Given this list of marker genes Irx2, Sostdc1, Dspp, Npr3, Egr3, Mesp1, Lrp5, Tulp3, Hs6st1, Gpx1 (NCBI Gene Id 14775), Fyn, Prrx1, Tbx4, Rgcc, Plg, Rbpj, Chi3l1, Jmjd8, Csmd1, Ptk2, Adam15, Hnf1b, Anxa1, Minar2, Ift57, Ptpn6, Traf6 (NCBI Gene Id 99098), Ephb3, Tcf7l2, Vangl2, Lep, Vegfb, Ctns, Ets1, Shroom3, Angptl6, Adrb2, Sall4, Tnfaip2, Ctnnbip1, Pank2, Vegfc, Rara, Pax2, Tnn, Hgf, Nr2f2, Itgax, Gpr15, Pfn1, Wdr83 (WD repeat domain containing 83, NCBI Gene Id 67836), Rapgef3, Tctn1, Timeless (timeless circadian clock 1), Sfrp2, Tert, Aimp1, Efna1, Fzd6, Notch4, Bmper, Itga7, Sema4c, Cd34, Ccl11 (C-C motif chemokine ligand 11), Foxc1, Hs3st3a1, Hbegf, Plcd1, Rnf213 (NCBI Gene Id 672511), Sox9, Gpld1, Sox4, Bcl2l11, Enpep, Ccl12 (NCBI Gene Id 20293), Bbs4, Zfp354c, Ctsl, Igf2, Uts2r, Pik3ca, Cdc42, Smad4 (NCBI Gene Id 28063), Shox2, Sp100, Ptger4, Id2, Btrc, Lef1, Grhl2, Unc5b, Dvl2, Col3a1, Hc, Vav3, Stat1, Fgf18, Fgf1, Srpk2, Foxn4, Hmga2, Ramp2, Mir27a, Ctnnd1, Hdac7 (NCBI Gene Id 56233), Anxa3, Bmpr1a, Wnt7b, Paxip1, Ddah1, Rhoa, Dlg5, Clec14a, Tbx2 (T-box 2, NCBI Gene Id 21385), Hoxa5 (NCBI Gene Id 15402), Itga2b, Tafa5, Cav3, Ctsh, Zic3, Ift122, Pf4, Cd36, Gatad2a, Robo4, Gab1, Kdm2a, Mcam, Ago2, Yjefn3, Mecom (NCBI Gene Id 58253), Epha7, Tnfsf12 (NCBI Gene Id 21944), Stk3, Stil, Fat4, Psg22, Adm (NCBI Gene Id 11535), Ctsz, Stk4, Yap1, Gli3, Amot, Greb1l, Ihh (NCBI Gene Id 16147), Kctd10, Thsd7a, Prl7d1, Atp2b4, Ppp1r16b, Sema4a, Thbs4, Abl2, Gdf2, Prox1, Pik3cg, Myo18b, Ang4, Csnk2b, Efnb2, Notch2 (NCBI Gene Id 99749), Rela, Mylk, Jup, Prkaca, Tgm2, Thbs1, Smad2, Adamts16, Sulf1, Srf (serum response factor), Nphp3, Pten, Epas1, Ccm2, Cnmd, Il10, Naa15, Tnfrsf1a, Myc, Casp3, Pax3, Emilin1, Hes5, Setdb2, Fgfr2, Tal1, Nkx2-5, Pkhd1, Ecm1, Cobl, Prrx2, Spint2, Syk, Rtn4, Id1, Cd40, Krit1, Emcn, Rdh10, Klhl3, Kras, Mir216a, Egfl7, Xbp1, Pknox1, Gpr4, Nkx2-1, Il1b, Myo1e, Sall1, Foxa1, C3ar1, Ramp1, Ndp, Ntrk1, Zeb2, Mthfd1l, Plcd3, Dchs1, Sema6a, Nkx2-3, Lama5, Qki, Smarca4, Gdnf, Areg (amphiregulin), Prkca, Dcn, Fap, Dnaaf1, Nfatc1, Dlg1, Ldlr, Phb2 (prohibitin 2), Jak1, Fgf6, Deaf1, Lmo4, Wnk4, Ccn1, Grn, Fgf8, Pgk1, Fn1, Prl2c2, Mmrn2, Hrg, Tgfbr1, Akt1, Pparg, Meox2, Fmnl3, Mical2, Ephb2, Il18, Cd160, Gadd45a, Igf1, Ghrl, Anxa2 (annexin A2), Cfh, Ppp1r15a, Sox17, Hhex, Mydgf, Srpx2, Dsg2, Tnmd, Tmed2, Tmem100, Fgf2, Actg1, Tmtc3, Dag1, Wnt4, Adgrf5, Ddr1, Notch1, Mef2c, Agtr1a, Tcf7, Nr4a3, Rasip1, Sfrp5 (NCBI Gene Id 54612), Nckap1, Enah, Adgrf4, Stra6, Tfap2c (NCBI Gene Id 98784), Sox10, Ang5, Becn1, Foxj2, Brd2, Irx3, Tmem215, Fasl, Ccdc39, Cldn5, Cfc1, Wasf2, Serpine1, Tnni3, Sgcd, Aplnr, Mir216b, Zfp36l1, Rala, Smad3, Card10, Epn2, Adra2b, Emx2, Sars1, Vhl, Ppp3r1 (protein phosphatase 3, regulatory subunit B, alpha isoform (calcineurin B, type I)), Mir27b, Fgf9, Mmrn1, Apoe, Amotl1, Cfl1, Ski, Cspg4, Hes1, Ngfr, Sp1, Hey1, Mks1, Mib1, Il12a, Rnh1, Col18a1, Vasp, Pik3c2a, E2f2, Tsc2, Ptprj, Hipk2, Mmp19, Pbx1, Tnc, Ephb1, Sox8, Brca1, Etv5, Ift172, Hoxd13, Cx3cl1, Angptl3 (NCBI Gene Id 30924), Hspb1, Rab23, Heg1, Prok1, Ccl5, Trim71, Rora, Foxm1, Pdgfb (NCBI Gene Id 18591), Six1, Mir145a (microRNA 145a), Acvr1, Cav1, Cripto, Tlr3, Src, Mir143, Tjp1, Nkx3-1, Zfpm2, F3, Fkbpl, Vdr, Acvr2b, Eng, Abcc8, Cxcr4, Map3k7 (mitogen-activated protein kinase kinase kinase 7), Prkd2, Plxnd1, Rspo2, Plau, Prdm1, Asb4, Cdh5, Klf5, Spry1, Ccdc103, Lrp2, Pml, Lox, Lrg1, Junb, Kif20b, Vps4b, Vav2, Sema3e, Tead2, Hand2, Bcas3, Mgp, Nr4a1 (nuclear receptor subfamily 4, group A, member 1), Ago1, Cybb, Esm1, Mapk7, Hey2, Pecam1, Nr2e1, Stard13, Plcg1, Has2, Foxf1, Kat6a, Wnt11, Cdk20, Egfr, Ppp1ca, S1pr1, Smad5, Adtrp, Vash1, Egfl8, Clic3, Jag1, Tbx20, Foxa2, Sox18, Cxcr3, Adgrg1, Tiparp, Ccdc40, Ccl2, Agtr2, Msx2, Il12b, Epo, Calcrl, Apold1, Cul7, Nodal, Mapk14 (mitogen-activated protein kinase 14), Pik3r3, Klf2, Zic2, Rock1, Arhgap35, Angpt4, Glul, Dll1 (NCBI Gene Id 13388), Creb3l1, Rxra, Six4, Cluap1, Thy1, Rock2, Tcf21, Fzd8, Pkm, Hoxa11, Adam12, Agr2, Ninj1, Col4a1, Cemip2, Acvrl1, Hgs, Hectd1, Alox5, Rhoj, Mir329, Kdm2b, Smad7, Dysf, Plxnb2, Pgf, Gja1, Sec1, B4galt1, Epb41l5, Nrxn3, Adamts12, Scg2, Wars2, Hspa12b, Aldh1a2, Osr1, Prkacb, Lrp1, Ehd4, Pkd1, Ism1, Dact1, Rbpms2, Scrib, Hoxb3, Cxcr2, Casp8, Col8a2, Nrcam, Esr1, Hdac5, Ptprb, Trp63, Fgfr3, Fzd4, Cx3cr1 (NCBI Gene Id 13051), Cela1, Itgav, Apln, Angpt2, Hoxb13 (NCBI Gene Id 15408), Cib1, Loxl2, Rap1a, Prkcb, Ang6, Mtdh, Adipor2, Ctsd, Gbx2, Mrtfb, Nog, Abl1, Col4a3, Epor, Lias, Ccbe1, Eda, Naxe, Myocd, Rasa1, Fzd3, Zeb1, Nrp2, Epha2, Rtl1, Wnt3a, Or10j5, Apaf1, Mecp2, Ovol2, S2bpcox16, Foxo4, Xdh, Lbx1, Myh9, Cd93, Ccn3, Lcn2, Sh2b3, Cc2d2a, Klf4, Pacsin2, Agt, Tbx1, Itgb2l, Vash2, Grem1, Pspn, Tmem59l, Rarg, Zc3h12a, Rapgef2, Stab1, Ednra, Ccn6, Arhgap24, Sgpl1, Bcl10, Eif2ak3, Tfap2a, Map2k5, Hlx, Psen1, Med12, Cited1, Pdgfra, Bcam, Prok2, Dll4, Htatip2, Pxdn, Adm2, Coq7, Shc1, Pnpla6 (patatin-like phospholipase domain containing 6), Fmn1, Casr, Cysltr2, Kdr, Tcf4, Ccr3, Gpc3, Npr2, Nrxn1, Brpf1, Mir217, Ntn1, Ngp, Cma1, Tek, Tspan12, Nrp1, Plk2, Mir23b, Zmiz1, Ext1, Hdac9, Sema5a, Pdgfrb, Gjc1 (NCBI Gene Id 353069), Stim1, Prickle1, Efna3, Tnfrsf12a, Fut1, Ptk2b, Nfatc4, Gata4, Egln1, Stat3, Prcp (NCBI Gene Id 72461), Notch3, Ntrk2, Flna (filamin, alpha), Foxp1, Elk3, Btg1, Wnt1, Tfap2b, Mia3, Kat2a (NCBI Gene Id 76912), Il17f, Tspan18, Ang (NCBI Gene Id 11727), Eya1, Mdk, Mtss1, Kif26b, Hspb6, Otulin, Cep290, Slc31a1, Itgb1bp1 (integrin beta 1 binding protein 1), Ackr3, Serpinf1 (NCBI Gene Id 20317), Nedd4, Itgb3, Nup50, Rhob, Cysltr1, Nfe2l2, Thbs2, Pitx2, Pik3cb, Egf, Folr1, Adgrb2, Col8a1, Erap1, Lzts2, Ahr, Pik3cd, Med1, Ccn2 (NCBI Gene Id 215862), Hif1a, Pkd2, Runx1, Synj2bp (synaptojanin 2 binding protein), Reck, Cxcl10, Alox12, Angpt1, C2cd3, S100a1, Nrarp, Ptch1, Jam3, Chd7, Smad6, Pde3b, Trp73, Hif3a, Epha1, Hesx1, Ecscr, Arhgap22, Jmjd6, Chrd, Csf1, Meis1, Lhx2, Gja5, Dab2ip, Epn1, Wars1, Smad1, Spint1, Ctnnb1, C3 (complement component 3), Optc, Edn2, BC028528, Isl1, Phactr4, Foxh1, Robo1, Tie1, Met, Wnk1, Bmp4 (bone morphogenetic protein 4), C1galt1, Sparc, Arid1a, Nox1, Esrp2, Nr3c1, Tacstd2, Bax, Mir126b, Tgfa, Hs2st1, Kif3a, Opa1, Dvl1, Pdcl3, Ar, Edar, Fgfr1, Tsc1, Pax8, Nus1, Rspo3, Ceacam1, Micall1, Ryr2, Foxd1, Gna13, Tgfbr3, Fkbp10, Lif, Tgif1, Wnt2b, Wnt6, Bmp5, Nfib, Percc1, Amotl2, Lepr, Atoh8, Tead1, Hyal1, Ncoa3, Ret, Nipbl, Fzd5, Zfp950, Glmn, Pak4, Wnt9b, Fgf3, Vegfd (NCBI Gene Id 14205), Spry2 (sprouty RTK signaling antagonist 2), Agtr1b, Arid2, Ndnf, Aqp1, Rps7, Foxn1, Hhip, Nf1, Minar1, Angptl4, Ptk7, Stox1, Bak1, Rgma, Enpp1, Apela, Sdc4, Fgfbp1, Ubp1, Vstm4, Sfrp1, Gata3, Irx1, Gzf1, Noto, Maged1, Adgrb1, Wnt5a, Hoxa7, Nras (NCBI Gene Id 99853), Tmem67, Anpep, Flt1, Adgrb3, Slc12a2, Itgb8, Wnt7a, Adamts1, Mir24-2, Tmem201, Apoh, Gata2, Mfge8, Epha4, Il1a, Atp5f1b, Apob, Pdcd6, Ang2, Lemd3, Hspg2, Ereg, Mmp9, E2f8 (E2F transcription factor 8), Smarca1, Shank3, Setd2, Ptn, Ipmk, Pxn, Stx2, Nprl3, Pthlh, Slc1a1, Zic5, Adam8, Crhr2, Hoxb7, Hpse, Hand1, Cecr2, Meis3, Ywhaz (NCBI Gene Id 68643), Gata6, Hs3st3b1, Map3k3, Col4a2 (collagen, type IV, alpha 2), Cdh13, Esrp1, Jun, Cdh2, Adgra2, Ilk, Pik3r2, Tbxa2r, Flt4, Grhl3, Pbrm1, Tcap, Clic4, Etv4 (ets variant 4), Spi1, Mst1, Sox11, Pdgfa, Podxl, Pdcd10, Parva, Cthrc1, Aggf1, Megf8, Serpinf2, Foxc2, Rras, Lrp6, Naglu, Npnt (nephronectin), Rin2, Prkx, Tgfbi, Ccdc134, Bmp2, Nppc, Pak1, Lama1, Ace, Nos3 (NCBI Gene Id 71933), Add1, Tgfbr2, Cyp1b1, Cited2, Wt1, Hoxa1, Hpgd (NCBI Gene Id 234274), Sec24b, C5ar1, Tgfb1, Commd5 (COMM domain containing 5), Cxcl17, Shh, Lhx1, Fbxw7, T, Prkd1, Sirt1, Mmp2 (NCBI Gene Id 17390), Lgr5, Cdh1, Etv2, Bmp7, Slit2, Rnf207, Gdf7, Cd44, Cxcl12, Vezf1, Tgfb2, Hoxd11, Dlc1, Smoc2, Hk2, Hoxa13, Adamts9, Dicer1, Pdpn, Foxp4, Sox2, Perp, Ptgs2, Emp2, Hmgb1, Ccl24, Sash1, Ptprm, Bsg, Fgf10, Mthfr, Jcad, Mir24-1 (NCBI Gene Id 387184), Tbx3, Spred1, Itga5, Gtf2i, Camp, Wnt2, Mmp14, Mycn, Itgb1, Comp, Gm28729, Six2, Kdm5b, Lgr4, H2-M3, Sufu, Atf2, Shb, Sdccag8, Flvcr2, Uts2, Hmox1, Pik3r6, Itgb2, Efemp2, Lgals3, Epgn, Emilin2, Pdpk1, Pofut1, E2f7, Bcl2, Luzp1, Gli2, Fbln5 (NCBI Gene Id 23876), Edn1, Arl13b, Cd59a, Hoxa3, Mthfd1, St14, Mir23a, Nfatc3 (NCBI Gene Id 97460), Slc39a12, Ephb4, Bmpr2, Cd47 (CD47 antigen (Rh-related antigen, integrin-associated signal transducer)), Smo, Akt3, Specc1l, Alx1, Tnf, Sirt6, Sos1, Sphk1, Ptgis, Asb2, Ncl, Kdm6a, Ift52, Ghsr, Rbm15, Ccr2, Fuz, Celsr1, Emc10, Vegfa, Pgr, Twist1, here is a description of the gene set: The process in which the anatomical structures of a tube are generated and organized. Epithelial and endothelial tubes transport gases, liquids and cells from one site to another and form the basic structure of many organs and tissues, with tube shape and organization varying from the single-celled excretory organ in Caenorhabditis elegans to the branching trees of the mammalian kidney and insect tracheal system. Mouse Gene Set: GOBP_TUBE_MORPHOGENESIS studied in species Mus musculus